Given this list of marker genes SMAD2, IPO8, COL5A1, PCGF2, ATP7A, here is a description of the gene set: Human Gene Set: HP_CAROTID_ARTERY_TORTUOSITY studied in species Homo sapiens Carotid artery tortuosity Abnormal tortuous (i.e., twisted) form of the carotid arteries.